The following is a description of a gene set: Human Gene Set: GOBP_REGULATION_OF_TRANSCRIPTION_REGULATORY_REGION_DNA_BINDING Any process that modulates the frequency, rate or extent of transcription regulatory region DNA binding. studied in species Homo sapiens, and this is the list of marker genes: HAND2, IGF1, RB1, HEY2, DAZAP2, H1-0 (H1.0 linker histone), ZBTB7A, NEUROD1, GTF2B, NIBAN2, TWIST1, GATA1, SOX11, GATA3, FOXC1, IFNG, POU4F1, ZC4H2, ZNF593, PSEN1, TRIM6, DOT1L, RNF220, POU4F2, NSD1